Given this list of marker genes NSUN2, GDF5, EZH2, UBAP2L (ubiquitin associated protein 2 like), DPH2, ARID1B, EVC (NCBI Gene Id 7886), RBPJ, TBX3, EIF5A, SHANK3, NPM1, APC, TBL2, CLIP2, GLI1, INPPL1, RFC2, BCR, WLS, WRAP53, ARHGAP31 (Rho GTPase activating protein 31), LIG4 (DNA ligase 4), CPT2, PARN, SOX4 (SRY-box transcription factor 4), DYNC2LI1, ELN, HRAS, NECTIN4, PPP1CB, DNAJC30, KCNH1, TMEM270, SHOC2, FTO, BUD23, KCNN3, MSX1, ERI1, GTF2IRD1, TELO2, NSD1, MAPK1, KRT14, SMARCA2, CRKL, GPC4, TYMS, SMARCB1, DLL4, SMARCD1, STX1A, SET, ODC1, NCF1, GTF2I, LIMK1, NHP2, VPS37D, EBF3, TBX4, ARID2, SCO2, NOTCH1, RTEL1, COL11A1, AFF4, ZMYM2, ZIC3, FKBP6, TCTN3, ATP6V1B2, NOP10, NOG, SOX11, POLR1A, DPH1, METTL27, SMARCE1, PORCN, SUZ12, PRKACB, EIF4H, PRKACA, USB1, TBC1D24, EOGT, DSP (desmoplakin), PPP2R5D, TERC, CKAP2L, JUP, SLC35D1, COL7A1, GTF2IRD2, TINF2, EVC2, DKC1, BAZ1B, SMARCC2, RIPK4, WNT7A, DPF2, DOCK6, ARID1A, KRT5, TERT, CTC1, HOXA13, SMARCA4, SHOX, PIGF, KDM1A, FGFR1, LRP4, here is a description of the gene set: Absence or underdevelopment of the toenail. studied in species Homo sapiens Human Gene Set: HP_APLASTIC_HYPOPLASTIC_TOENAIL Aplastic/hypoplastic toenail